Given this list of marker genes C5ar2, C5ar1, C3ar1, Cr1l, Nptxr, here is a description of the gene set: Combining with an opsonin and transmitting the signal from one side of the membrane to the other to initiate a change in cell activity. studied in species Mus musculus Mouse Gene Set: GOMF_OPSONIN_RECEPTOR_ACTIVITY